The following is a description of a gene set: Human Gene Set: GSE6566_STRONG_VS_WEAK_DC_STIMULATED_CD4_TCELL_DN Genes down-regulated in CD4 cells stimulated with strong dendritic cells (DC) versus CD4 T cells stimulated with weak DCs. The strength of T cell stimulation determines IL-7 responsiveness, recall potential and lineage commitment of primed human CD4+IL-7Rhi T cells. We analyzed how the strength of antigenic stimulation - as determined by dendritic cell (DC) number, DC maturation state and antigen concentration - controls in human CD4+ T cells IL-7R-alpha expression and responsiveness to IL-7, IL-15 and antigen. We found that T cells primed by different strengths of stimulation expressed IL-7R-alpha in different proportions and preferentially on cells that maintained expression of the central memory marker CCR7. However, while CCR7+IL-7Rhi cells generated at high strength of stimulation proliferated vigorously in response to IL-7 or IL-15, CCR7+IL-7Rhi cells generated at low strength of stimulation responded poorly. High cytokine responsiveness was associated with reduced PTEN expression and enhanced s6-kinase activation, consistent with efficient receptor coupling to downstream signalling pathways. Interestingly, while intermediate-stimulated CCR7+IL-7Rhi cells were non-polarized, self-renewed with IL-7 and expanded with antigen, high-stimulated cells generated Th1 effector cells with cytokines but showed impaired IL-2 production and survival with antigen. Gene expression analysis suggested that high-stimulated cells represented pre-Th1 cells with low recall potential and high metabolic state. Taken together these results demonstrate that IL-7 receptor expression and coupling are instructed in T cells by the strength of stimulation and suggest that memory subsets may derive from CCR7+IL-7Rhi precursors that received different strengths of stimulation. from publication Lozza L, Rivino L, Guarda G, Jarrossay D, Rinaldi A, Bertoni F, Sallusto F, Lanzavecchia A, Geginat J (PMID 18081042) studied in species Homo sapiens, and this is the list of marker genes: HSPA1L (NCBI Gene Id 3305), PAX8-AS1, GATB, ITGB7, WASH3P, SLC38A4, MIEF2, MARCHF2, COG2, CTNND1, MORC2-AS1, IL16, BCORP1, TIPARP-AS1, ODF4, SMC1B, SMIM19, STK10, RHBDD2, SPON1, EOLA1-DT, KLC2, OPRK1, KLRB1, MS4A3, P2RX4, QNG1, MIR155HG, LRRIQ3, TRIM11, NAGPA, ZNF263, URB2, TECTB, NBDY, KCNC3, TAFA1, FIS1, PIP5K1C (phosphatidylinositol-4-phosphate 5-kinase type 1 gamma), ARHGEF9, ADGRL3, GPR183, TMEM17, IYD, ZNF527, ICAM3, ZNF786, CUX2, UBASH3A, LAIR1, CNPY1, MYL12A, ATP6V0E2, PTPN12, MEN1, BMPR1A, NCK2, ATP6AP1-DT, CD96, LINC00324, SUGP1, ZNF883, SYNE1, HECTD3, TIGIT, MFNG, FPGS, HSD17B11, PLCL1, CYP24A1, SRSF8, ENSG00000235138, CTBP1, LRPAP1, PRKCA, CTTNBP2, LINC02481, CCR6 (NCBI Gene Id 1235), NUDT16L1, TMBIM1 (transmembrane BAX inhibitor motif containing 1), RPS21, ZNF879, RPS16, CYP4V2, COX19, GIMAP5, MMP1, TAFA2, SLC41A3, KLRA1P, MAGEB3, TPT1, RPL6, TMEM86B, ZBTB45, ZFPM2, SLCO1C1, TBC1D10C, RPS6KA1, OR7A17, ZFP36L1, LAPTM5, BEX2, NUDT13, NPL (NCBI Gene Id 80896), SPARCL1, GNAQ, CNDP2 (NCBI Gene Id 55748), URB1, NLRP7 (NCBI Gene Id 50956), PIK3IP1, USH2A, TMEM80, KYNU, CYP7B1 (cytochrome P450 family 7 subfamily B member 1), ANKRD13C-DT, PAQR8, DHRS1, PPP2CB, AKR1C3, GARS1-DT, FAM168A, CSK, ERC1, LTB, PKIG, ZNF32, CARTPT, CCDC181, PCA3, KRT73, DHRS11, ZNF394, CCDC174, VPS52, ADGRA3, SNHG7, COMMD7, ELAC1, WDR48 (WD repeat domain 48), ADCK1, CERS6, RIN3, HSD17B1, PITPNC1, NIPA1, RPS27L, VPS11, MED24, LMO7DN, TFIP11, ATP5F1E, PTGER4, C11orf68, GYPB (glycophorin B (MNS blood group)), HUWE1, RSL1D1, GNPTG, ABHD14A, ESRP2, EEIG1, USP45 (ubiquitin specific peptidase 45), CCNY, BRD7P3, FBXO28, LPXN, RPS20, TOR1A, OR5V1, GPR6, OR51B4, NGRN, SMAD2, SLC12A7, RBM23, MBTPS1, EID3, TBCEL, TAF3, CACNA2D4, ZZEF1, TTC21B, IGHV7-81, MAP1LC3B, DAOA-AS1, ZSWIM3, KLHDC9, CD83, EXOC3, MARCHF3